Given this list of marker genes MYD88, ATP6AP1, ASXL1, TREX1, MTRR, SBDS, RPS29, SRSF2, DNAJC21, ALDOA, HK1, EFL1, SF3B1, TOR1A, TET2, TPI1, KIT, here is a description of the gene set: Normocytic anemia Human Gene Set: HP_NORMOCYTIC_ANEMIA species: Homo sapiens A kind of anemia in which the volume of the red blood cells is normal.